Given this list of marker genes Plcg1, Prkd1, Plg, Hif1a, Notch1, Hdac5, Nr2e1, Robo4, Pik3c2a, Ets1, Fgfbp1, Tnf, Adam17, Card10, Hspb1, Amotl1, Epha2, Hmox1, Tbxa2r, Nf1, Alox12, Anxa1, Gab1, Fgf18, Pdcd10, Sp1, Map2k3, Prl7d1, Mecp2, Map2k5, Pdgfb, Atp5f1b, Meox2, Tgfb1, Nos3, Col18a1, Hrg, Itgb1bp1, Rhoj, Hdac7, Sirt1, Mmrn1, Efna1, Hdac9, Mef2c, Angpt2, Fgf2, Tgfbr3, Srpx2, Stat5a, Dll4, Prkd2, Ptgs2, Rhoa, Nrp1, Thbs1, Angpt1, Spred1, Foxc2, Fgfr1, Nus1, P2rx4, Abl1, Prkca, Mmrn2, Akt3 (thymoma viral proto-oncogene 3), Hmgb1 (high mobility group box 1), Vegfc, Map3k3, Cd40, Prl2c2, Stard13, Kdr, Pik3r2, Cib1, Vash1, Pparg, Pdpk1, Klf4, Angpt4, Rgcc, Jcad, Vegfa, Csnk2b, Igf1, Akt1, Tmsb4x, Acvrl1, Igf2, Jup, Prcp, Fbxw7, Amot, Atp2b4, Sh3bp1, Plk2, Gata2, Nfe2l2, Apoe, Gadd45a, Atp5f1a, here is a description of the gene set: Mouse Gene Set: GOBP_REGULATION_OF_BLOOD_VESSEL_ENDOTHELIAL_CELL_MIGRATION studied in species Mus musculus Any process that modulates the frequency, rate or extent of the migration of the endothelial cells of blood vessels.